Given this list of marker genes Slc2a5, Cd2ap (NCBI Gene Id 98065), Cers1, Myc, Ahi1 (NCBI Gene Id 67502), Nfe2l2, Oga, Mef2a, Capn10, Sirt6, Pid1, Enpp1, Rhoq, Mfn2, Fgf21, Tert, Slc2a4, Fgf15, Rap1a, Gpc3, Erfe, Ocln, Stxbp3, Itln1, Slc27a4, Drd1, Igf1, Klf15, Slc2a1, Adipor2, Ins2, Upk3b, Hk2, Rasa1, Tnf, Ptpn11, Acacb, Rtn2, Zdhhc7, Irs1, Sort1, Rab4b, Mapk14, Insr, Slc27a1, Sorbs1 (NCBI Gene Id 75688), Prkcd, Lep, Ostn, Rnasel, Akt1, Trarg1, Pth, Slc2a3, Septin7, Hnf1a, Rps6kb1, Gsk3a, C1qtnf12, Slc2a2, Repin1, Ace, Prkci, Appl1, Akt2, Grk2, Irs2, Aspscr1 (NCBI Gene Id 68938), Slc1a2, Prkca, Pea15a, Erbb3, Slc2a7, C2cd5, Opn3, Slc25a27, Sh2b2, Grb10, C1qtnf2, Erbb4, Ins1, Dhrs7c, Osbpl8, Sesn2, Crebl2, Sgcb, Adipoq, Appl2, Pou4f2, Slc2a9, Esr1, Tsc2, Tsc1, here is a description of the gene set: species: Mus musculus The directed movement of the hexose monosaccharide D-glucose into a cell or organelle. Mouse Gene Set: GOBP_D_GLUCOSE_IMPORT